Given this list of marker genes HCST, NACA, LDLRAD2, MT-CYB, IGFBP7, PIK3R1, BAALC, C1QTNF4, PROM1, B2M, BCL3, PFDN5, ATP5F1E, BTF3, PTPRCAP, TMSB4X, MT-TL1 (NCBI Gene Id 4567), HINT1, HOPX, GSTP1, LMNTD1, ANGPT1, MT-ND4, FAU, CD99, NAP1L1, CSF3R, GYPC, CD48, CD52, DYNLT1 (dynein light chain Tctex-type 1), PADI4, ATP5MC2, ARHGAP30, SPNS3, ACTG1, PRAM1, SNHG8, MT-ND3 (NCBI Gene Id 4537), HLA-A (major histocompatibility complex, class I, A), S100Z, SNHG5 (small nucleolar RNA host gene 5), SNHG6, RACK1, HLA-C, RILPL2, MT-CO1, IGLL1, ERLIN1, EGFL7, ENO1, HSH2D, RUNX1, FLT3, EIF3K, SMIM24, SNRPD2, HLA-B, CD44 (NCBI Gene Id 960), IGHM, IFITM1, GAS5, MACROH2A1, FAM30A, SELL, NUCB2, CALHM6, RCSD1, PSME1, SPINK2 (NCBI Gene Id 6691), MZB1, VMP1, EEF1B2, GNG11, IFITM3, HNRNPA1, TPT1, MPG, ITM2C, CD74, TPM4, ARHGAP25, HLA-DRA, ZFAS1, ADA, NPDC1, MAP3K8, UBA52, COMMD6, RNASET2, MT-CO3, S100A4, RASGRP2, TSC22D3, GAPDH, CD34, ERGIC1, here is a description of the gene set: from publication Zheng S, Papalexi E, Butler A, Stephenson W, Satija R (PMID 29545397) Human Gene Set: ZHENG_CORD_BLOOD_C8_PUTATIVE_LYMPHOID_PRIMED_MULTIPOTENT_PROGENITOR_2 studied in species Homo sapiens